The following is a description of a gene set: Neighborhood of DEAF1 studied in species Homo sapiens Neighborhood of DEAF1 deformed epidermal autoregulatory factor 1 (Drosophila) in the MORF expression compendium Human Gene Set: MORF_DEAF1, and this is the list of marker genes: DEAF1, YARS1, NDUFS4, POM121, IARS1, ESD, HADH (hydroxyacyl-CoA dehydrogenase), MRPS27, MTREX, AK2, TARS1, SAFB, EIF3I, CDC16, SDHB, SRP72, HNRNPR, LRPPRC (leucine rich pentatricopeptide repeat containing), NUDC, TXNL4A, CAMKK2, TREX2, XPO7, TOMM70, IPO7, PRKDC, UPF3A, GTF2A2, KHSRP, VDAC3 (voltage dependent anion channel 3), GARS1, LSM2, ATP5MC3, EPRS1, PPP1CC, NDUFV1, SF3A3 (splicing factor 3a subunit 3), ATP5PO, IMMT, VDAC2, CS, IMPDH2, PABPC4, DNAJC11 (NCBI Gene Id 55735), KXD1, MRPS18B, DCTD, PTDSS1, NDUFS2, AFG3L2, FH, RAD23A, DKC1, ANP32A, AKR7A2, NPM3, HDDC2